Given this list of marker genes ASXL2, SMG1, HMGA1, SLC16A2, CTNND2, USP2, NIPBL, ARID4A, PRMT3, GPS2, BMP7, JADE2, E2F8, OSBPL7, ZCCHC8, KCNA6, RANBP1, TMEM131L, CASP2, SUV39H1, ERG (NCBI Gene Id 2078), FANCC, KPNB1, POLA2, GLRA3, MTF2, POLE4, ZMYM2, ATE1, DMRT1, EZH2, SMC6, E2F3, FBXO5, H1-3, PCNA, RCOR2, TOP1, SRSF2, DDX17, HNRNPD, AP1S2, TNPO2 (transportin 2), ERF, TIPIN, SALL1, AP4M1, ZNF827, CASP8AP2, KLF5, ANP32E, GEN1 (GEN1 Holliday junction 5' flap endonuclease), MAZ, NHLRC2, SRSF1, PTMA, IMPDH2, STX5, DCK, HOXA9, NDUFA11, FAM219A, NEGR1, NCL, PIK3R4, GMNN, RIBC1, TRMT2A, GPRC5B, HOXC10, SREK1, ZBTB8OS (zinc finger and BTB domain containing 8 opposite strand), H2AZ1, SERBP1, PCDH7, YBX2 (NCBI Gene Id 51087), TBX3, SMC3, PPP1R8 (NCBI Gene Id 5511), RSRC2, RELT, TUBA3E, PIK3R3, FHIP1B, DCTPP1, PATZ1, AGFG2, GPAT2, UCHL1, ID3, GINS3, STT3B, ADAMTS2, DOLK, DCLRE1A, EPHB1, SFMBT1 (Scm like with four mbt domains 1), MAT2A, E2F1, KMT5A, PRPF38A, CDC25A, STAG1 (NCBI Gene Id 10274), SMC2, ZNF362, ZIM2, NECTIN1, EVA1B, CSRNP1, ARHGAP36, DIO3, CBX5, MCM7, PODN, PPRC1, INTS7, DAXX, YWHAQ, WEE1, ORC1, SIK2, CDC6, SEMA5A, PAQR4, MXD3, RBBP4, IPO11 (NCBI Gene Id 51194), TRIR, RAD51, SASS6, MAP3K13 (NCBI Gene Id 9175), GATA3, RFC1, FBXL20, MEIS2, IER5L, ERBIN, ZNF687, PDS5B, ETV4, UXT, CITED2, OVOL2, ATP5MC2, ACBD6, NCOA6, TOPBP1, PPP1R9B, DNMT1, PRIM1, TMEM255A (NCBI Gene Id 55026), DLST, SMC1A, PPM1D, UNG, CTDSPL2, EIF3K, THAP8, NASP, PAN2, WDR62, MCM2, HMGN2, MCM3, CDC45, KNTC1, ZNF367, PRKDC, JPH1, PCLAF, RPS19, POLA1, ADGRB1, FAM120C, CTCF, STMN1, PLK4, UFD1, ANKHD1-EIF4EBP3, FBXO9, TRMT13, FANCG, LUC7L2, PCYT2, EPHB2, DNAJC5G, NSD3, IPO7, ZNF565, SYT11, NRP2, POLE2, TMEM187, NUTF2, H2BC10, MCM4, MCM6, EIF5A, SSU72, ABCF2, FAM216A, PKMYT1, RBPJ, TIAM1, CDC20B, CNBP, BRMS1L, CDCA7, STAG2, ANKHD1, KCND2, MELK, HNRNPA1, PEG3, RPS6KA5, GAPDH, FMO4, SLBP, ARHGAP11A, SLC38A1, RAB11B, MYC, SLC6A4, DDB2, DNAJC11, DMD, MAP4K1, RNF121, GPN3, ZDHHC17, E2F7, JADE1, KDM3A, PCSK4, ATAD2, USP49, NR3C2, DPYSL2, here is a description of the gene set: Genes having at least one occurrence of the motif NCSCGCSAAAN in the regions spanning 4 kb centered on their transcription starting sites. This matches the E2F, TFDP1 transcription factor binding site V$E2F_Q4_01 (v7.4 TRANSFAC). Human Gene Set: E2F_Q4_01 species: Homo sapiens